The following is a description of a gene set: Human Gene Set: GOBP_CYTOPLASMIC_PATTERN_RECOGNITION_RECEPTOR_SIGNALING_PATHWAY species: Homo sapiens The series of molecular signals initiated by the binding of a ligand from another organism to a cytoplasmic pattern recognition receptor (PRR). PRRs bind pathogen-associated molecular pattern (PAMPs), structures conserved among microbial species., and this is the list of marker genes: RIGI, ABHD8 (abhydrolase domain containing 8), LILRA4, FBXL2, OAS3, BANF1, PYDC5, USP17L2, HSPA8, CYLD, MIR708, SLC19A1, AURKB, TSPAN6, RNF135, TAB1, ABHD17A, PELI1, TREX1, NLRP1, MARK4, RSAD2, PRKDC, SPSB3, TNF, NOD2 (nucleotide binding oligomerization domain containing 2), CGAS, NOP53, ZDHHC18, USP15, FLOT1 (NCBI Gene Id 10211), IRGM, ZDHHC5, OAS1 (2'-5'-oligoadenylate synthetase 1), CSNK1A1, NLRC3, NFKBIA, KCNJ8, GBP5, IRF3, ANKRD17, PTPRS (protein tyrosine phosphatase receptor type S), ZCCHC3, OASL, TLR4, FLOT2, SLC15A2, TREML4 (NCBI Gene Id 285852), NEK7, HMGB1, TRIM31, NLRP6, IRAK4, PUM2, C1QBP, PRKD1, ZDHHC9, NLRP2B, SCARA3, PHB2, WASHC4, TLR9, CARD8, BIRC3, IRF7, GBP2, PYDC1, NLRP3, PHB1, ERBIN, RTN4, RIOK3, RFTN1, PTPN22, TREM2, SIRT2, PARP1, TIRAP, TAX1BP1, TICAM1, XIAP, TLR8, MYD88, LYPLAL1, UBQLN1, SEC14L1, TBK1, ZC3HAV1, EIF2AK2, GPATCH3, IRF5, PUM1, HDAC6, ZDHHC12, RAB7B, USP50, ATAT1, ZDHHC1, HAVCR2, OTULIN, AARS2, TNIP2, KCNK13, TRIM65, IFI16, STMP1, TKFC, TRAF3IP3, HCFC2, UNC93B1, FCRL3, NLRX1, PYCARD, HSPA1B, STING1, IKBKB, TARBP2, BRCC3, PPP6C, TIFA, KCNK6, SMPDL3A, TASL, TLR6 (NCBI Gene Id 10333), SCIMP, GKN2, MAVS, YWHAE, BIRC2, CD36, MARCHF5, LACC1, UFD1, DDX3X, SLC15A3, PLCG2, EPG5, TLR7, MAPK8, CPTP, IPO5 (NCBI Gene Id 3843), TRIM15, ITCH, CLPB, MEFV, IFIH1, CAV1, RELA, ZNRF4, TRIM3, NPLOC4, OGT, TRIM25, PYDC2, MAP3K7, DDX41, COLEC12, GRAMD4, DHX33, RNF170, NOD1, HSPA1A, ZDHHC3, LATS2 (large tumor suppressor kinase 2), SLC15A4, SRC, LSM14A, RNF125, ALPK1, NAGK, PPT1, WDFY1, SLC46A2, RNF39, MIR4691, NR1H4, BTK, TLR3, IRAK1, BECN1, ELP6, PIK3AP1, RIPK2, PPP2CA, DDX60, DHX58, TNFAIP3, AKT1, LATS1, P2RX7 (purinergic receptor P2X 7), TRAF6, INAVA, TRIM11, LAMP2, MAP2K6, PCBP2, F2RL1 (F2R like trypsin receptor 1), RNF34